Given this list of marker genes HFE, NCKAP1L, HLA-E, SH3RF1, RUNX3, CLEC4A, CD274, BCL2, HLA-A, TOX (NCBI Gene Id 9760), TNFSF8, RUNX1, VSIR, CBFB, SLC4A2, GPR18, SOCS1, CRTAM, IRF1, LILRB4, EOMES, WDFY4, DAPL1, MAPK8IP1, PSMB11, LILRB1, XCL1, ZBTB7B, here is a description of the gene set: The change in morphology and behavior of a CD8-positive, alpha-beta T cell resulting from exposure to a mitogen, cytokine, chemokine, cellular ligand, or an antigen for which it is specific. Human Gene Set: GOBP_CD8_POSITIVE_ALPHA_BETA_T_CELL_ACTIVATION studied in species Homo sapiens